Given this list of marker genes Igf2r, Rab8a, Atp7a, Rassf9, Ap1m1 (adaptor-related protein complex AP-1, mu subunit 1), Synrg, Ap1g1, Cltb, Rab14, Aftph, Rab13, Ap1s1, Tgoln1, Rab27b, Gopc, Cltc, Steap2, Slc2a4, Slc18a3, Sort1, Ap1m2, Spg21, Ap1s2, Tmed10, Ap1s3, Clrn1, Ap4b1, Nrgn, Lyz2, Ap1b1, Lyz1, Ap1g2 (adaptor protein complex AP-1, gamma 2 subunit), Rab8b, Furin, Rab12, Clta, Clba1 (clathrin binding box of aftiphilin containing 1), here is a description of the gene set: Mouse Gene Set: GOCC_TRANS_GOLGI_NETWORK_TRANSPORT_VESICLE A vesicle that mediates transport between the trans-Golgi network and other parts of the cell. studied in species Mus musculus